Given this list of marker genes Cdc25a, Bbip1, Adnp, Supt5, Rev3l, Uba2 (ubiquitin-like modifier activating enzyme 2), Nt5m, Oga, C2cd3, Fbxo38, Proser1, Srsf2, Dclre1b, Ccdc124, Tob1, Gjb4, Gm14137, Sall3, Tmbim1, Banp, Nprl3, 1700028E10Rik, 4930430O22Rik, Nosip (nitric oxide synthase interacting protein), Cacna2d2, Znhit3, Lrch4, Sema5b, Sbno1, Arrdc3, Psmc5, Jmjd6, Nudt13, Shd, Ubap2l, Gpc1, Gm20605, Dnm3os, Mynn, Ccdc174, Dusp23, Sp3os, Tsku, Cep350, Prkcsh, Hexim2, Pnrc1, Pnpla6, Zfp628, Phf21a, Krt80, Nr2f6, Trak2, 2310001K24Rik, Pkdcc, 2700033N17Rik, 4933434E20Rik, Eri2, Tns1, Gm15335, Bmpr1a, Rptor, Eed, Ankrd40, Srsf1, Irf2bpl, Pip4p2, Adam17, Tango6, Fbxo24, Gm25582, Ap4b1, Tomm40, Rc3h1, H3f3a, Oaz2, Gm26604, Gm9694, Mfsd11, Zfand3, 2610005L07Rik, Memo1, Mir8114, 2900052L18Rik, Palld, Wiz, Gm27239, 4930539J05Rik, Rsrc1, Rps27, Gm10484, Odad3, Cxxc4 (NCBI Gene Id 83381), Vldlr, Wbp1l, Mbnl1, Sgce, Gm9967, Farsa, Mfap1b, Msl1, Krtap4-9, Iscu, Cacna1h, Cdca2, Kmt2c, Gsk3b, Tubb5, Ftsj3, Eif4a1, Nabp2, Supt3, Nedd4, 2500004C02Rik, Lman1, Rpl5, Mir3569, Kmt2b, Spink10, Sumo3, Appl2, Dclre1c, Ears2, Fzd2 (NCBI Gene Id 57265), Psmb6, Tuba1b, Sdhaf3, Hnrnpc, Mir199a-2, Rnf220, Gatad2b, Sec16b, Pramel12, Rsf1, Ggn, Zfp608, Dolpp1, Zfta, H3c6, Ccne2, Ntaq1, Mir7-2, Ctnna1 (NCBI Gene Id 66546), Cct7, Cltc, Rpia, 4930481B07Rik, Nhlrc3, Cdk9, Fbxl20, Dnajc30, Gm15322, Kat6b, Scaf11, Ercc6l, Ambra1 (autophagy/beclin 1 regulator 1), Ptpru, Vps26c, Ctnnbl1, H2ac5-ps, Actb, Oxsr1, Marcksl1, AI849053, Rundc3a, Pcif1, H2bc4, Dlx6os1, Zc2hc1a (NCBI Gene Id 99818), Ube2g1, Cacna2d1, Dnajc1, Brd10, Nup153, Exoc7, Helt, Ncoa6, Crk, Ciao3, Hdac2, Glul, Arid3a, Aanat, Gm6822, Syncrip (synaptotagmin binding, cytoplasmic RNA interacting protein), Cyb561, Sox2, Mllt3, Mir2861, Slc4a1ap, Mzf1, A730013G03Rik, Kctd5 (potassium channel tetramerisation domain containing 5), Cntnap2, Utp4, Cops7b, Prorp, Cdk14, Hmgb1, Gm13575, Prrg2, Kctd9, Ctnnb1, Ypel3, Igf2bp3, Wipf2, Mapk1, Zfp687, Supt7l, Cbx3, Kmt2a, Nufip2, Phf13, Gm11175, Tvp23a, Dot1l, Mir6991, Pten, Nme1, Shoc2, Foxj2, Insr, Sart3 (squamous cell carcinoma antigen recognized by T cells 3), Arid1a, Ube2d3, BB218582, E230029C05Rik, Peg10, Tssk6, Rbm25, Hnrnph1, Fermt2, Hspa8, Setdb1, Tmem38b, Gm12415, H3c3, Pcbp4, Pradc1, Pfdn4, Chtf8, Aamdc, Zfp408, Arhgap1 (Rho GTPase activating protein 1), Lemd2, Atxn7l3, Acvr2b, Gm28818, Vwf (Von Willebrand factor), Ptpn12, H4c4, Tead2, Sgk2, Fbxl18, Mthfr, Mis18bp1, Rbm4b, G630016G05Rik, Ppme1, Spred3, Nxt1, Atp5mc3, Fbxo11, Dlx2, H2ac6, Uqcrh, Fitm2, Ppih, Rab6a, H2bc3, Luc7l, Fam110a, Anapc15 (anaphase promoting complex C subunit 15), 1810059C17Rik, Tnrc18, Msl2, Ubfd1, Osbp, Pdgfc, Acly, Rexo5, Casz1, Mettl23, 1700023H06Rik, 4930579D09Rik, Ttc17, Ccl9, Map1lc3b, Med6, Rab4a, Lrrc41, Bud23, Sox4, Zfp24, Mir3960, Trpm7, Rab13, Srcin1, Morf4l1, Sp3, St3gal2, Tbkbp1, Mir100hg, Susd6, Cp, here is a description of the gene set: species: Mus musculus from publication Yevshin I, Sharipov R, Kolmykov S, Kondrakhin Y, Kolpakov F (PMID 30445619) Mouse Gene Set: DLX1_TARGET_GENES Genes containing one or more binding sites for (Dlx1) in their promoter regions (TSS -1000,+100 bp) as identified by GTRD version 20.06 ChIP-seq harmonization.